The following is a description of a gene set: studied in species Homo sapiens Human Gene Set: HP_EPISODIC_PAIN Episodic pain Intermittent pain, i.e., pain that occurs occasionally and at irregular intervals., and this is the list of marker genes: ERBB3, MRAP, NF1 (NCBI Gene Id 646021), SLC25A11, CPT2, CDKN1B, TXNRD2, DNMT3A, EPAS1, SDHD, ATRX, SDHC, MEFV, SDHAF2, MAX, SDHB, MDH2 (malate dehydrogenase 2), TRPA1, TGFBI, NNT, LPL, PIGA, CDC73, FH, MC2R, DLST, RET, ESR1, PNPT1, SDHA, STAR, TMEM127, GNE, KIF1B, HEXB, VHL, FLI1, LEMD3, F12